The following is a description of a gene set: Mouse Gene Set: GOBP_AGGRESSIVE_BEHAVIOR studied in species Mus musculus A behavioral interaction between organisms in which one organism has the intention of inflicting physical damage on another individual., and this is the list of marker genes: Crhbp, Nlgn4l, Gcnt4, Tacr1, Oxt, Trpc2, Nr2e1, Penk, Avp (NCBI Gene Id 11998), Abl2, Kirrel3, Avpr1a